The following is a description of a gene set: The transcription export (TREX) complex couples transcription elongation by RNA polymerase II to mRNA export. The complex associates with the polymerase and travels with it along the length of the transcribed gene. TREX is composed of the THO transcription elongation complex as well as other proteins that couple THO to mRNA export proteins. The TREX complex is known to be found in a wide range of eukaryotes, including S. cerevisiae and metazoans. Mouse Gene Set: GOCC_TRANSCRIPTION_EXPORT_COMPLEX species: Mus musculus, and this is the list of marker genes: Alyreffm3, Thoc6, Thoc2l, Alyreffm8, Alyref2, Alyreffm7, Ddx39b, Zc3h11a, Alyreffm1, Sarnp, Chtop, Thoc3, Thoc7, Alyreffm10, Alyreffm6, Thoc5, Nxf1, Alyreffm9, Alyreffm4, Alyreffm5, Thoc1, Thoc2, Alyref (Aly/REF export factor), Alyreffm11